Given this list of marker genes NOTCH2NLA, RPL36AL, PTPRC, UBN1, PAN2, SRSF5, RBM5, ABAT, ZNF136, ZNF83, CX3CR1, PBXIP1, VWA5A, ZFAND6, INSIG2, CREBBP, AAK1, MSL3, GIT2, TRIOBP, YPEL5, CD6, NHERF1, IGFBP3, TXK, TES, ZNF337, P2RX4, HLTF, MXI1, UPF3A, CCDC28A, TNKS2, EPB41, CD96, AZU1 (azurocidin 1), PMS2P3, WDR26, DIPK1A, LIPT1 (NCBI Gene Id 51601), USP34, NHLRC2, TUT4, FOXO3, C11orf21, IFT20, ZNF137P, AKT3, CCNL2, ZC3H11A, DAZAP2, BMPR2, GSTK1, TMBIM4, EIF3H, RNF113A, UBE2H (NCBI Gene Id 7328), CAPN2, C6orf120, BSDC1 (NCBI Gene Id 55108), MRNIP, BRD1, ARL4C, EHD1, RB1CC1, IRAK4, MYCBP2, CIRBP, AKAP13, MACF1, TSC22D1, PARP6 (poly(ADP-ribose) polymerase family member 6), PDP1, ASXL2, FBXL14, CYFIP2, EPM2AIP1, CD44, WSB1, PIAS1, RBL2, RPL11, CCSER2, PIK3CA, APBB1IP, ZNF32, CASC3, ZNF767P, KMT2A, ADD3, ZFP36L1, BRD3, ZNF500, ADRB2, GCC2, CLK1, MAPK14, S1PR4, MAML1, GPR18, GMFG, TMEM41B, SON, PRSS23, PAFAH1B1, PCNX2, NISCH, MAN1A2, USP4, PIGC, RUNX1, PBX2, KLF12, CBLB (NCBI Gene Id 868), LGALS8 (galectin 8), DYNLT3 (dynein light chain Tctex-type 3), PSIP1, OGT, ECHDC2, CES2, ZNF839, TRIM52, CLK4, BTN3A1, EXOC1, MSL2, ARMCX3, LY9, DGKD, TCF20, ZHX2, FBXW4P1, PPP3CC, ABCC5, RSRC2, BTN2A1, STAT4, ITGA4, CD37, NDRG1, EBLN2, GUSBP3, VPS26A, ARGLU1, ING4, ABI1, ING3, CBFA2T2, CLEC2B, ELF1, USP3, ATP8A1, LYRM9, S1PR1, ANKRA2, ENPP4, ZNF211, ASAH1, C2CD5, N4BP2L1, SETD2, CTDSP1, CEP350, ANKRD49, MPHOSPH8, TTLL3, AAMDC, WWP1, CLDN15, OSBP, ADA2, ZNF189 (NCBI Gene Id 7743), SNX29P2, POU2F1, DPP8, LEMD3, RPL13, CLASP1, ABR, SATB1, NR2C1, SYF2, RPL39, PKN2, PGPEP1, SLC46A3, ALMS1, DPEP2, IP6K2, VAMP4, NACA, FBXO9, PTCH1, RPS20, BANP, ZMYND8 (zinc finger MYND-type containing 8), MFAP3 (NCBI Gene Id 4238), YIPF6, SNHG32, here is a description of the gene set: from publication Marigo I, Bosio E, Solito S, Mesa C, Fernandez A, Dolcetti L, Ugel S, Sonda N, Bicciato S, Falisi E, Calabrese F, Basso G, Zanovello P, Cozzi E, Mandruzzato S, Bronte V (PMID 20605485) studied in species Homo sapiens Genes up-regulated in CD11b+ from spleen of healthy C57BL6 versus CD11b+ cells from tumors of C57BL6 mice bearing EL4 lymphoma. Human Gene Set: GSE21927_SPLEEN_C57BL6_VS_EL4_TUMOR_BALBC_MONOCYTES_UP Tumor growth is associated with a profound alteration of myelopoiesis, leading to recruitment of immunosuppressive cells known as myeloid-derived suppressor cells (MDSCs). Analyzing the cytokines affecting myelo-monocytic differentiation produced by various experimental tumors, we found that GM-CSF, G-CSF, and IL-6 allowed a rapid generation of MDSCs from precursors present in mouse and human bone marrow (BM). BM-MDSCs induced by GM-CSF+IL-6 possessed the highest tolerogenic activity, as revealed by the ability to impair the priming of IFN- -producing CD8+ T cells upon in vivo adoptive transfer. Moreover, adoptive transfer of syngeneic, GM-CSF+IL-6-conditioned MDSCs to diabetic mice transplanted with allogeneic pancreatic islets resulted in long term acceptance of the allograft and correction of the diabetic status. Cytokines inducing MDSCs acted on a common molecular pathway. Immunoregulatory activity of both tumor-induced and BM-derived MDSCs was entirely dependent on C/EBP transcription factor, a key component of the emergency myelopoiesis triggered by stress and inflammation. Adoptive transfer of tumor antigen-specific CD8+ T lymphocytes resulted in therapy of established tumors only in mice lacking C/EBP in myeloid compartment. These data unveil another link between inflammation and cancer and identify a novel molecular target to control tumor-induced immune suppression. We used gene expression analysis to identify those factors, secreted by tumor-infiltrating MDSC, which could drive emathopoiesis. Moreover we compare gene expression profile of tumor-induced MDSC, obtained from either the spleen and the tumor infiltrate of tumor bearing mice, and in vitro bone marrow-derived MDSC.